Given this list of marker genes SPSB4, NAV3, ZNF138, KIF14, SEPTIN5, ABHD15, SNX8, BACH2, TTPAL, RSAD1, IL36RN (NCBI Gene Id 26525), GATA3, OTUD1, RND3, DCAF10, NUDCD3, FAM114A2, DENND5A (DENN domain containing 5A), SLC25A42, FOSL2, MMP11, ZBTB43, MMP16, DHX38, CUL5, SLC9A5, ZFP41, TBL1XR1, DAD1, CAMK1G, OXR1, PISD, ZNF75A, PCMTD1, RRP7A, NFAM1, PARD3B, TCFL5, ENTREP2, LDLRAD4, ERC1, SCML2, GALNT10, LPP, KCNC1, CTDSPL2, STK38L, CBR1, F2RL2, UBAP2, NEK6, CD40, RGS9BP, SLC24A3, ACP6, SPTY2D1, ZNF182, SYNPO2, WDR93, RXFP1 (relaxin family peptide receptor 1), HMGA2, PLA2G12B, GCNA, TULP4, CLEC12A, KCNJ13, PLAC8, ATXN1, MYCBP, HNRNPA1, TMEM144, ZNF268, SIT1, HNRNPA1L2, SLC6A17, RAB10, CREM, RWDD1, PLCH1, ATP11A, DDX6 (NCBI Gene Id 1656), FRMD5, EVC, WDTC1 (NCBI Gene Id 23038), ATXN7L1, here is a description of the gene set: Human Gene Set: MIR1976 Genes predicted to be targets of miRBase v22 microRNA hsa-miR-1976 in miRDB v6.0 with MirTarget v4 prediction scores > 80 (high confidence targets). species: Homo sapiens from publication Chen Y, Wang X (PMID 31504780)